The following is a description of a gene set: species: Mus musculus Mouse Gene Set: REACTOME_RHOG_GTPASE_CYCLE RHOG GTPase cycle, and this is the list of marker genes: Dock4, Lamtor1, Tfrc, Arhgdig, Cav1, Arhgap39, Mpp7, Prex1, Ankle2, Hspe1-rs1, Cyfip1, Iqgap2, Dock5, Elmo2 (NCBI Gene Id 73997), Vav3, Emd, Arhgef16, Arhgap32, Ndufs3, Arhgdib, Pik3r1, Letm1 (NCBI Gene Id 56384), Trio, Vapb, Vrk2, Ophn1, Rab7, Hspe1, Arhgap35, Arhgap21, Ktn1, Mcf2l, Kalrn, Vav1, Dsg2 (desmoglein 2), Stx5a, Rhog, Pgrmc2, Itsn1, Pak4, Pak2, Dock2, Plekhg3, Depdc1b, Erbin, Mcf2, Vav2, Esyt1, Arhgap1, Ykt6, Mcam, Map3k11, Arhgef26, Arhgef5, Stbd1, Lman1, Shmt2, Arhgap5, Vangl1, Itgb1, Cdc42ep1, Rbm39, Dock1 (dedicator of cytokinesis 1), Arfgap3, Lbr (NCBI Gene Id 98386), Ndufa5, Vamp3, Arhgdia, Cdc42, Epha2, Diaph3, Garre1